The following is a description of a gene set: Human Gene Set: GOBP_NEGATIVE_REGULATION_OF_MORPHOGENESIS_OF_AN_EPITHELIUM studied in species Homo sapiens Any process that stops, prevents or reduces the frequency, rate or extent of morphogenesis of an epithelium., and this is the list of marker genes: TBX2, TNF, SULF1, WNT5A, MIR21, BMP7, TACSTD2, CTNND1, BMP4